The following is a description of a gene set: Human Gene Set: GOBP_IRIS_MORPHOGENESIS studied in species Homo sapiens The process in which the iris is generated and organized. The iris is an anatomical structure in the eye whose opening forms the pupil. The iris is responsible for controlling the diameter and size of the pupil and the amount of light reaching the retina., and this is the list of marker genes: FOXE3, WNT2 (Wnt family member 2), HIPK1, HIF1A, WNT2B, HIPK2, WNT9A, PITX2, PAX6